Given this list of marker genes Pnck, Zer1, Timm17b, Slc38a1, Pik3c3, Kl, Sftpa1 (surfactant associated protein A1), Cotl1, Son (Son DNA binding protein), Emilin3, Misp3, Usp50, Nfix, Zfp609, Prkca, Tigd5, Zfp106, St8sia2, Aldoa, Mxi1, Hs3st2, Col1a1, Abcg4, B4galt2, Mfng, Jmjd8, Mpl, Clcnka, Abcf2, Gm6878, Slc36a1, Trabd, Recql, Atf7ip, Nnat, Sema4g, Phf24, Bod1l, Phc3 (polyhomeotic 3), Mdga1, Slc38a3, Acot11 (acyl-CoA thioesterase 11), Fkbp5, Socs3, Cbx6, Larp1, Crat, Rexo1, Tagln, Nectin1, Cep170b, Kcnk3, Igsf8, Mras, Zfp568, Ctdp1, Neu2, Atg4b, Slc1a7, Cuedc1, Pdpn, Rapgef1, Kcnip3, Zbtb4, Tanc2, 5031439G07Rik, Wdfy3, Tgs1 (trimethylguanosine synthase 1), Ap1m1, Dagla (diacylglycerol lipase, alpha), Ucp2, Mb, Zfp219, Zfp617, Ncstn, Pfkfb4, Tnrc6b, Kcnk5, Cbfa2t3, Irf2, Fam163a (family with sequence similarity 163, member A), Wipf2 (WAS/WASL interacting protein family, member 2), Gnai2, Rap1gap2, Sh3pxd2a, Thap11, Plekhb2, Creb5, Dlg2, Ptpn23, Carns1, Cdc42se1 (NCBI Gene Id 99930), Natd1, Gsk3a, Pacs1, Grin1os (NCBI Gene Id 320354), Aldoart1, Mlc1, Txlna, Hip1 (huntingtin interacting protein 1), Grm2, Gprc5c, Stk39, Tmem222, Abl1, Zfp821, Slc8a1, Samd4b, Thbs4, Fbxo41, Adgra2, Stk40, Map6d1 (NCBI Gene Id 208158), Gpr107, Zfp446, Anks1b, Slc16a6, Hectd3, Gnao1, Sprtn, Hnrnpk, Cyp26b1, Zfp92, Znrf1, Osbpl5, Xpo7, Sdc3, Mettl26, Adgrl1, Adarb2, Iqsec2, Rnf150, Zhx3, Bptf, Kcng1, here is a description of the gene set: Genes predicted to be targets of miRBase v22 microRNA mmu_miR_7648_3p in miRDB v6.0 with MirTarget v4 prediction scores > 80 (high confidence targets). Mouse Gene Set: MIR_7648_3P species: Mus musculus from publication Chen Y, Wang X (PMID 31504780)